The following is a description of a gene set: from publication Tien MT, Girardin SE, Regnault B, Le Bourhis L, Dillies MA, Coppée JY, Bourdet-Sicard R, Sansonetti PJ, Pédron T (PMID 16394013) Shigella invades the human intestinal mucosa, thus causing bacillary dysentery, an acute recto-colitis responsible for lethal complications, mostly in infants and toddlers. Conversely, commensal bacteria live in a mutualistic relationship with the intestinal mucosa that is characterized by homeostatic control of innate responses, thereby contributing to tolerance to the flora. Cross-talk established between commensals and the intestinal epithelium mediate this active process, the mechanisms of which remain largely uncharacterized. Probiotics such as Lactobacillus casei belong to a subclass of these commensals that modulate mucosal innate responses and possibly display anti-inflammatory properties. We analyzed whether L. casei could attenuate the pro-inflammatory signaling induced by Shigella flexneri after invasion of the epithelial lining. Cultured epithelial cells were infected with L. casei, followed by a challenge with S. flexneri. Using macroarray DNA chips, we observed that L. casei down-regulated the transcription of a number of genes encoding pro-inflammatory effectors such as cytokines and chemokines and adherence molecules induced by invasive S. flexneri. This resulted in an anti-inflammatory effect that appeared mediated by the inhibition of the NF-kappaB pathway, particularly through stabilization of I-kappaBalpha. In a time-course experiment using GeneChip hybridization analysis, the expression of many genes involved in ubiquitination and proteasome processes were modulated during L. casei treatment. Thus, L. casei has developed a sophisticated means to maintain intestinal homeostasis through a process that involves manipulation of the ubiquitin/proteasome pathway upstream of I-kappaBalpha. Human Gene Set: TIEN_INTESTINE_PROBIOTICS_24HR_UP species: Homo sapiens Genes up-regulated in Caco-2 cells (intestinal epithelium) after coculture with the probiotic bacteria L. casei for 24h., and this is the list of marker genes: DNAJA1, HMGCS1 (3-hydroxy-3-methylglutaryl-CoA synthase 1), RPA3, DAB2, BRD8, GLUL, PSMC1, CHTOP, SUCLA2 (succinate-CoA ligase ADP-forming subunit beta), RCN2, H3-3B, FOXM1, CSRP2, NFATC2IP, SEH1L, C12orf43, NUP188 (NCBI Gene Id 23511), FBXO3, RBM14, KIF11, DHX9, ZWINT, BABAM1, DLGAP5, BRD9, SYNGR2, SMIM10L1, NDUFB6, TBL1X, KIF14, SMC4, SDHC, COMMD9, DCXR, ZC3HAV1, DHCR7, REEP5, MORC2, MGST2, MAPK1IP1L, FABP1 (NCBI Gene Id 2168), NUSAP1, FAIM, ANP32E, CDC25A, TMPO, SPAG5, PUDP, SRSF2, NR2F2, NDUFB2, CENPS, TAGLN, CRIPT, ADAR, PANK3, AP5M1, PGAM1, ENDOD1, PIN4, UNG, SPAST, SNRPD3, TRMT61B, MMD, COMMD8, SKP2, MRPL22, TIMM23, LGALS2, NUP85, NIP7, PNN, UBAC1, NDUFA5, CDKN3, MPHOSPH6, FBXO5, CREG1, MAP4K4, PSMC6 (proteasome 26S subunit, ATPase 6), ARHGAP8, CDC42EP3, HIBCH, NCAPH, EIF4A3, RAPGEF2, WASHC2C, KLHL7, LGR4, HSPA14, ADI1 (acireductone dioxygenase 1), RBX1, TM7SF3, AMMECR1, UMPS, LMNB2, PAIP1, POLDIP2, NDUFB3, NEMP1, ARL4C, EED, RBM8A, SPG7, FAM32A, FKBP4, CIAPIN1, C11orf24 (NCBI Gene Id 53838), SUPT16H, TMA7, CETN3, NME1, FDPS, SLC25A44, TPCN1 (two pore segment channel 1), MED4, NEDD8, RRM2, POP5, FEN1, IFT25, TCAF1, YWHAQ, DHCR24, BUB1B, POLE2 (NCBI Gene Id 5427), MTCH1, DCK, C1D, NPTN, DYNLL1, MORC4, MCM4, ATP1B1, KRIT1, APOD, LSM5, MTRR (NCBI Gene Id 4552), VRK1, MAP3K4, LSM4, CRYBG2, LSS, GMFB, HPGD (NCBI Gene Id 3248), NUDC, EXOSC7, TK1, GGH, SRSF1, FCF1, MCM2, CEP76, LMAN2L, CYBC1, WDR82, TNPO1, PRDX2, NOP56, ETF1, SKIC8, RAN, PHACTR2, RP2 (NCBI Gene Id 6102), ATOX1, LAPTM4B, PSME3, TUBG1, SLC25A4, MCM6, ACLY, SIVA1, HNRNPH3, MYH10, SLC1A1, GLRX5, MRPL9, PCNA, DYNLT1, GTF2H5, DDX52, ADSL, CENPI, HTATSF1, CBFB, ACAT2, HACD2, SNX3, RBM12, NDUFC1, HSDL2, LSM7, GGA2, CPSF6, CCND1, SNRPF, ETNK1, HPRT1 (hypoxanthine phosphoribosyltransferase 1), TTF2, PHB1, ABCD3, FUS, MSH6, ASAH1, NDUFA13 (NCBI Gene Id 619501), SMARCA5, ERH, ISOC1, FAM98A, TCF4, UBE4A, DNAJC9 (NCBI Gene Id 23234), RIN2, RRM1, TAF11, ATP5MG, TGOLN2, CYB5B, EMG1, SNN, SUMO1 (NCBI Gene Id 7341), PDHX, GEMIN4, SLIRP, SLC25A13, HSPE1, SGK1, IMPA2, ATP5PF, ERCC3, RDH11, SLC9A6, NAE1, RFC2, GOLGA7, TM4SF1, ACOT13, HARS1, LARP4, SAC3D1, CKS2, USP7, C1QBP (complement C1q binding protein), DCAF6, PCMT1, PLCB1, HNRNPAB, RRP15, RTL8C, SNRNP25, TARDBP, DICER1, ST14, PAFAH1B1, VAMP8, SGMS1, HNRNPA3 (heterogeneous nuclear ribonucleoprotein A3), TCEAL4, EIF4E, PDHB, DGCR2, PLXNA1, CYB5R3, CHMP5, HMGN3, TIMM13, IL32, HEG1, DHX29, KIF20A, AGPAT5, CELF1, AGMAT, MGRN1, MRPL46, FKBP3, WBP11, AREL1, HNRNPA0, AURKAIP1, ATP13A3, TIMM8B, AHSA1, RAD51AP1, CMTM6, GLDC (NCBI Gene Id 2731), PLEKHB2, POMK, TRIP13, TIPIN, CCNB1, SRSF7, RARS1, UROD, TBRG4, MCM7, CCNA2, SRSF5, UNC50, PIK3R4, NDUFA8, DBF4, GINS2, TIGAR, IARS2, DERA, LINC01399, UBE2N, POLR3K, RPA1, TMEM177, SRRT, CUL2, SAMM50, TSN, FASTKD1 (FAST kinase domains 1), ESPL1, DUT, PALM2AKAP2, CALM1, MGST3, DAG1, MRPS22, PEPD, DDX46, GET1, TPM1, CAST, RACGAP1, C5orf15, THYN1, GTF3C2, SPON1, NDUFB1, GINS1, QDPR, DIMT1, EI24, AFG2B, SRSF3, CSTF3, TNS3 (tensin 3), NDUFA9, DDC, ATP6V0E1, FASTKD5 (NCBI Gene Id 60493), GALNT6, SYNCRIP, PICALM, PSMA6, DROSHA, PEX3, ALDH7A1, CDC123, ARF3, TOPBP1, TYMS, FARP1 (FERM, ARH/RhoGEF and pleckstrin domain protein 1), TAGLN2, ERLIN1, VAMP3, ID2, CKLF, PCBD1 (NCBI Gene Id 5092), DBI, TMEM109, LARS2, COX17, MFSD1, ICMT, ABAT, CLUH (NCBI Gene Id 23277), SFPQ, H2AZ2, FASTKD3, RECQL, PDF, RFC3, HNRNPM, SHCBP1, VDAC3, GTSE1, FBXO9, PPIF, MYL6, APOC3, PRSS23, HEATR3, ACTN1, MRPS18B, OAT, SLBP, SNRPE, DEF8, RPL26L1, MSMO1 (NCBI Gene Id 6307), HMMR, NUP93, DCTPP1, BUB1, TEAD4, NDC80, RRP7A, SLC36A1, POLR2F, LRPAP1 (NCBI Gene Id 4043), FRMD4B, SNHG14, METAP2, SUB1, PPM1H, SPC25, CACYBP, MRS2 (magnesium transporter MRS2), PON2, CXADR, FAM111A, MED24, PFKFB3, NDUFA2, DENR, MSX2, DDX3X, SNRPD1, RBM34, MCM3, SHTN1 (shootin 1), UTS2, LPCAT1, ENTPD4, PSMD2, LRRC47, SC5D, PXMP2, ATP5MC3, ATP2C1, G3BP1, TRIAP1, UBE2D1, CENPA, ADM, STARD7, UBL5, RIC8A, NXT2, CENPN, LRPPRC, SMYD2, ERI2, TUBB2A, ARHGDIB, HCCS, HJURP, GINS3, TFAM, NUP107, CHI3L1, PSMB7, LSM3, ZFYVE16, MRPL20, GALNT1, CADM1, GMNN, ECHS1, CNPY2, MIOS, MRPS2, ACYP1, NDUFA6, EID1, DPP3, APOBEC3B, COA3, PGS1, TMEM14A, ENOSF1, AURKA, BCLAF1, ATP5MJ, SLC5A6, MAD2L1, SNRPG, CDC42, NSF, TRAPPC4, NDUFV2, COTL1, DHX15, SHLD2, PIGF, AMD1, LYRM2, GCH1, HTATIP2, HSBP1, DNMT1, ADAT1, TTC1, UBAP2L, TAX1BP3, BMI1, AASDHPPT, ATP5MF, NUDT15, INPP5A, PTS, TOMM6, TMEM50A, NASP (nuclear autoantigenic sperm protein), TRIM14 (tripartite motif containing 14), SAR1A, PSMD1, GM2A, PLK1, UBE2L3, LYRM4, MRPS28, CDK2AP1, USP11, CCDC86, MCM5, HMGCR, HIGD1A, TWNK, PPP2R1B, TRAPPC2L, KLHL21, DNAJC15, PDCD5, TBX3, DNMT3B, CENPF, ACAA2, KIF23, DOCK9, TOP2B, NTAN1, LUC7L3, SAMD4A, EBP, SAFB2, PACSIN2, IDI1, PTTG1, GNS, RAB8A, ALAD, OPA1, SLC25A1, CALD1, NLRP2, POLR2L, H2BC12, MPZL1 (myelin protein zero like 1), EXOSC2, NUDT1 (NCBI Gene Id 4521), PRC1, USP14, ERG28, HMGCS2